Given this list of marker genes HMGCS1, UAP1, ZBTB10 (NCBI Gene Id 65986), KLK2, DHCR24, UBE2I, PLPP1, STK39, BMPR1B, HMGCR, STEAP4, RAB4A, MAK, ANKH, ACSL3, SORD, CAMKK2, PTK2B, FKBP5, IQGAP2, ACTN1, ABHD2, TMEM50A, HPGD, SAT1, H1-0, GNAI3, SCD, TPD52, PA2G4, PIAS1, TNFAIP8, CDC14B, ALDH1A3, HOMER2, UBE2J1, SLC38A2, SGK1 (NCBI Gene Id 6446), ADAMTS1 (NCBI Gene Id 9510), KRT8, PMEPA1, MYL12A, ADRM1, CDK6, XRCC6 (NCBI Gene Id 94359), TMPRSS2, MAP7, B2M, RRP12, AKT1, ZMIZ1, SRP19 (signal recognition particle 19), XRCC5, INPP4B, CCND1, RPS6KA3 (NCBI Gene Id 6197), AKAP12, ELL2, IDI1, PDLIM5, SPDEF, AZGP1, SMS, NGLY1, ELOVL5, B4GALT1, TSC22D1, LMAN1, KLK3, KRT19, NDRG1, PTPN21, ARID5B, LIFR, SEC24D, GPD1L, GUCY1A1, HERC3, VAPA, SLC26A2, HSD17B14 (NCBI Gene Id 51171), ABCC4, PGM3, TARP, DNAJB9, SPCS3, MERTK, ELK4, DBI, FADS1, CCND3, GSR (NCBI Gene Id 2936), APPBP2, SRF, NKX3-1 (NK3 homeobox 1), MAF, ITGAV, CENPN, INSIG1, NCOA4, SELENOP, here is a description of the gene set: Genes defining response to androgens. from publication Liberzon A, Birger C, Thorvaldsdóttir H, Ghandi M, Mesirov JP, Tamayo P (PMID 26771021) Human Gene Set: HALLMARK_ANDROGEN_RESPONSE studied in species Homo sapiens